The following is a description of a gene set: Any process that modulates the frequency, rate or extent of skeletal muscle. studied in species Homo sapiens Human Gene Set: GOBP_REGULATION_OF_SKELETAL_MUSCLE_TISSUE_REGENERATION, and this is the list of marker genes: GJD4, PPARD, SPAAR, MYOZ1, CAPN3, MYOD1, P2RX5, HOPX, SOX15